The following is a description of a gene set: from publication Durant L, Watford WT, Ramos HL, Laurence A, Vahedi G, Wei L, Takahashi H, Sun HW, Kanno Y, Powrie F, O'Shea JJ (PMID 20493732) Human Gene Set: GSE21670_STAT3_KO_VS_WT_CD4_TCELL_TGFB_TREATED_UP STAT3, an essential transcription factor with pleiotropic functions, plays critical roles in the pathogenesis of autoimmunity. Despite recent data linking STAT3 with inflammatory bowel disease, exactly how it contributes to chronic intestinal inflammation is not known. Using a T cell transfer model of colitis we found that STAT3 expression in T cells was essential for the induction of both colitis and systemic inflammation. STAT3 was critical in modulating the balance of T helper 17 (Th17) and regulatory T (Treg) cells, as well as in promoting CD4+ T cell proliferation. We used chromatin immunoprecipitation and massive parallel sequencing (ChIP-Seq) to define the genome-wide targets of STAT3 in CD4+ T cells. We found that STAT3 bound to multiple genes involved in Th17 cell differentiation, cell activation, proliferation and survival, regulating both expression and epigenetic modifications. Thus, STAT3 orchestrates multiple critical aspects of T cell function in inflammation and homeostasis. species: Homo sapiens Genes up-regulated in CD4 T cells treated with TGF beta: STAT3 knockout versus wildtype., and this is the list of marker genes: AFF3, KCMF1, C1orf198, PIK3R4, C8orf76, RHOQ, IQCG, CINP, SLAMF7, MSL3, PSMD11, DPAGT1, LPGAT1, WBP4, MECR, NADK, ZMPSTE24, GPR25, INHA (NCBI Gene Id 3623), PDK3, ZNF202, DZIP3, SNHG3, MTHFD2, USP6NL, APEX1, PLAGL2, YARS1, UBE2F, AKR1E2, MRPL45 (mitochondrial ribosomal protein L45, NCBI Gene Id 84311), RABGGTB, RNF149, ELP4, CPT2, GNAQ, KLF15, PPP1R16A, FOXRED2, CARHSP1, AEN, HINFP, TMBIM1 (NCBI Gene Id 64114), PITHD1, CRYZ, E2F3, GOLGB1, CCT7, IER3 (NCBI Gene Id 91950), TSPAN6, WDR12, IDE, TRIM37, MIB1, SEMA6D, SLC7A6, DUSP19 (NCBI Gene Id 142679), C19orf67, UNG (uracil DNA glycosylase), PTGR2, COQ6, MRRF, SMYD3, CKAP4, DNAAF4, YAF2, SSX2IP, RAD54B, EIF4H, NVL, SIK2, POGK, XPOT, POLH, COQ3, CKAP2L, DHFR, OSBPL11, R3HDM1, TMEM41B, PRPF31, ANGPT4, POGLUT2, GEMIN4, PCBD2, SLC30A4, MTG1, CENPK, SH3RF1, LAPTM4B, ODC1, CAPG, N4BP2, CCNG1, TRAIP, COQ4 (coenzyme Q4), ABCC8, LUZP1, XRCC2, ZNF839, SLC7A1 (NCBI Gene Id 6541), FDFT1, P3H1, ERBB3, CASP7, DHX33, STIL, TRIM35, GPAM, MXD3, CDYL, COASY, USP47, PON1, CDKN2C, SCN5A, HR, KLHL22, DHCR24, FAM156A, F2R, PGK1, DNMT3B, RRP8, ZSCAN21, EEF1AKMT1, MCM10, MCM7, LZTR1, ZSWIM9, TBC1D22A, POLD3, PRNP, ELOVL1, XCL1, AP1G1, C2orf49, QSOX2, GPR68, TIMM17B, BBS12, KANK3, ADAT2, KNTC1, BTG3, SV2A, PKN3 (NCBI Gene Id 29941), MRPL44, ZNF496, WDR11, MMACHC, EXTL2, C9orf152, PRKCI, MUL1, HIVEP3, ATAD3A, LARS1, HAUS8, MYO1C, CDC6, NOC4L, ZNF475, GRAMD1B, RAB8B, RNF157, RBPJ, TTC39B, TTF2, USP27X, SCARF1, ZNF518B, CENPO, SERHL2, HLA-DMA, CDC14A, SLC7A6OS, POLE, ARL14EP, RSPH3, RNMT, SS18, RAB2B, SGSM3, TOP2A, SLC39A8 (NCBI Gene Id 64116), EYA3, POLA1, SPC25, CELSR2, STEEP1, LAMP2, RALYL, MARS1, LRFN4, MYB, PHF5A, FAM76A, SNX12, E2F7